Given this list of marker genes IL4R, IGFLR1, DKK3, SCML2, NMUR1, GSTO1, AURKAIP1, STAT4, DHX35, FLT3LG, LINC00302, CDC25B, GPC3, SPOCK2, VIM, CCNI (cyclin I), IRF9, PEX10, AGRP, CD6, MACROD1, IL16 (NCBI Gene Id 3603), XK, SLC2A4RG, MAPK14, ABHD14A, SELENBP1, NUP210, DHRS3, PMM2, MRPS34, TRBC1, ANXA2P3, PGAP3, FOXM1, NOD2 (nucleotide binding oligomerization domain containing 2), RPL12, PFDN5, TNC, HOXB8, COTL1, PCDH11Y (protocadherin 11 Y-linked), CTPS2, PPP4R3B, NFIC, CLTA, MTMR14, IMPA2, MEOX2, COL1A2, USP2, ARRB1, CORO7, LHX6, MCRS1, NFATC3, ZNHIT2, SLC22A4, SPTBN1, SART1, ID3 (inhibitor of DNA binding 3), DNPH1 (2'-deoxynucleoside 5'-phosphate N-hydrolase 1), MYO9B, SPAM1, CST3, ZKSCAN8, RCAN3, CTBP1, R3HCC1, KMT5A, HEXA-AS1, SARS2, SLC25A20, TCF20, TESPA1, MYBL2, YWHAH, IL7, PBXIP1, SDS, TTLL1, MKRN7P, SMIM14, ATF5, HIGD2A, ATP6V0A1, LARP4B, NDUFS6, NUDT1, DEF6, AQP2, APLP2, ACAA2 (NCBI Gene Id 147548), LST1, CCDC85B, ELOB, REG3A, SPANXC, CBX6, STEAP4, CD52, XCL1, DSN1, PPCDC (phosphopantothenoylcysteine decarboxylase), B4GALT7 (beta-1,4-galactosyltransferase 7), H2BC3, LCOR, MMP20, TXN2, GPR6, PNN, CLSTN1, CDCA8, PTPN9 (protein tyrosine phosphatase non-receptor type 9), GSTM5, SKAP1, GRHPR, VPS13D, NPFF, CIDEB, CTSS, BIN1, PRMT7, H2AC13, IGBP1, LMCD1, THEMIS2, CD59, MICU1, NR0B1, TPD52L2, POLR2L, NOC4L, CAB39L, H1-3, MAD1L1, RPL10, ADGRE1, ZNHIT1, MAPK1 (mitogen-activated protein kinase 1), RNF32, FAM171A1, RRAD, IQCE, ABCA7, LRRC32, CPT1A, MT1M (metallothionein 1M), CD3D, COMMD4, CAV1, LY6G5C, MYL6, ECI2, EPHX2, ST20, BHLHE40, SPINT2, CDK14, POU4F1, ZSCAN18, RMND5B, TNK2, KIF22, PTGIR (prostaglandin I2 receptor), FGF8, ATP5MF, DUSP10, S100A4, LMOD1, GMPR, AKR1A1, SPATA1, SSUH2, PSME1, FAM135A, MAP2K6, CHRNA6, H2AC14, CDKN2A, PRRC2B (NCBI Gene Id 84726), HCLS1, HS6ST1, CENPN, AGFG2, TEDC2, GPX4, ZKSCAN5, CAPG, EGFL6, PTBP1, LCK, MIER2, GUK1, SPTAN1, WRNIP1 (NCBI Gene Id 56897), CRIP1, EVL, here is a description of the gene set: Genes up-regulated in thymic macrophages versus medullary thymic epithelial cells (mTEC). studied in species Homo sapiens from publication Derbinski J, Gäbler J, Brors B, Tierling S, Jonnakuty S, Hergenhahn M, Peltonen L, Walter J, Kyewski B (PMID 15983066) Human Gene Set: GSE2585_THYMIC_MACROPHAGE_VS_MTEC_UP Gene expression in different thymic stromal cells and subsets thereof was analyzed in 6-12 week old wild type (C57BL/6) and Aire knock-out (mixed background) mice. Thymic stromal cells were purified by sequential enzymatic digestion (collagenase, collagenase/dispase and trypsin) followed by gradient centrifugation and FACS sorting. Sort criteria were as follows: dendritic cells (CD11c+, F4/80 -), macrophages (F4/80+, CD11c-), cTECs (CD45–/lo, CDR1/Ly51+, Ep-CAM+) and mTECs (CD45–/lo, CDR1/Ly51–, Ep-CAM+). mTECs of wild-type and Aire knock-out mice were further subdivided according to CD80 expression levels. For microarray analysis total RNA from thymic stromal cell samples of two independent experiments was pre-amplified and biotinylated by two rounds of cDNA synthesis and in vitro transcription. Fluorescence readings were evaluated by using Microarray Suite 5.0 software.